Given this list of marker genes TGFBR3, TGFB1, TGFBR1, TGFB2, BAMBI, AMH, TGFBR3L, TGFB3, ENG, LRG1, MAP3K7, here is a description of the gene set: Binding to a type II transforming growth factor beta receptor. Human Gene Set: GOMF_TYPE_II_TRANSFORMING_GROWTH_FACTOR_BETA_RECEPTOR_BINDING studied in species Homo sapiens